The following is a description of a gene set: from publication Chen Y, Wang X (PMID 31504780) Genes predicted to be targets of miRBase v22 microRNA mmu_miR_3064_5p in miRDB v6.0 with MirTarget v4 prediction scores > 80 (high confidence targets). Mouse Gene Set: MIR_3064_5P studied in species Mus musculus, and this is the list of marker genes: Clock, Igfbp5, Hspb6, Eif4a2, Nrp2, Eif4b, R3hdm4, Yrdc, Tmt1b, Fbxl17, Ap1g1, Rassf5, Klhl7, Cdip1, Gpn2, Zcchc4, Pik3cb (phosphatidylinositol-4,5-bisphosphate 3-kinase catalytic subunit beta), Zbtb3, Mink1, Il10ra, Maff, Pde1a, Proz, Eif5, Ctns (cystinosis, nephropathic), Sh3bgrl3, Igf2bp2, Adcy1, Rgl1, Tmbim1, Zfp12, Phactr4, Mettl21a, Bub3, Shank2, Appl2, Ppp4r2, Paqr4, Sap18b, Mmd2, Usb1, Btbd6, Dhdh, Map1lc3b, Rora, Otub2, Mrpl9, Sort1, Usf3, Slc36a1, Pmm2, Trem5, Shisa6, Lad1, Mecp2, Ndst1, Prkab1, Vash1, Nr4a3, Ptprj, Polr3f (NCBI Gene Id 76836), Klhl25, Rmi2, Slc35d3, Txnip, Sec14l3, Sptb, Rhoj, Zfand3, Pcsk5, Galnt10, Ube2ql1, Mtif3, Rnf26, Slf2, Reps2, Eeig2 (EEIG family member 2), Gsg1l, Atp1b4 (ATPase Na+/K+ transporting, beta 4 polypeptide), Sap18, Ago1, Dnah11, Wrn, Car10, Phf24, Xpnpep3, Pno1, Trps1, Trpm1, Lbh, Pax1, Tnrc18, Arhgap21, Lrrc32, Hcar2, Samd1, Akr1c19, Selenoi, Snn, Frmd4a, Gpr137b, Slc39a13, Phf21a, Tigd5, Pappa2, Olr1, 9930111J21Rik1, Mapre3, Amotl2, Septin12, Rorb, Ephb2, Spata1